Given this list of marker genes IPO11, MLH3 (NCBI Gene Id 27030), AK4, SMARCD1, ASB6, GNE, PRTG, TTI2, XYLT1 (xylosyltransferase 1), TVP23A, ARGLU1, TET3, BNC2, CLCN5, NPY2R, PDP2, MASP1, CASC3, PHETA2, XPO1, OLFM4, ZDHHC23 (zinc finger DHHC-type palmitoyltransferase 23), ITIH5, SEMA4F, AZIN2, HOXA1, FOXRED2, CRY2, PSD3, CBL, EPC1, CBX6, RPS24, CPSF6, KLHL7, DNMT3A, GRIN2A, ARFIP1, TMEM138, DHX58, SF3B4, RBBP7, BMP8A, BLMH, RBFOX1, NALF1, PTAR1, KCNJ5, LIFR, LY6G6C, CLMN, IQSEC2, MLLT11, FAM131B, SH3D19, E2F7, VSIG10, BSPRY, ZNF331, C5AR1, MMP15, NOVA2, ZC4H2, ARHGAP19, SEMA6A, CLDN18, HTR2C (NCBI Gene Id 3358), CD207, PRRC2B, RANBP10, DNM3, KRT31, SCAI, EOMES (eomesodermin), NAV1, GRPEL2, GSG1L, NAV2, USP30, PDE1C, SNX27, TCP11L1, KLHL30, TTLL7, SRGAP3, ZFP3 (ZFP3 zinc finger protein), C5AR2, GLYR1, HMG20A, ELMO2, YJU2, DUSP10, ADAMTS1, ZNF8, NIPAL4, SAMD4B, JPH3, PDE1A, LAMTOR3, COX10 (cytochrome c oxidase assembly factor heme A:farnesyltransferase COX10), NCSTN, CNTN1, KRTAP5-2, CWC27, SNX12, PRDM2, ANTXR2, ASPHD2, ELFN2 (extracellular leucine rich repeat and fibronectin type III domain containing 2), SSH2, SLITRK1, DEDD, ZBTB40, TBC1D8, LENG8, ZRANB1, KDM5A, ZBTB39, HOXB5, ADGRF2P, COL9A2, HAND1, EGFR, OAS2, LPP, FBXO11, CPT1A, AP1S3, PRICKLE2, F8, ADA, CDC14B, ZSCAN22, ZHX3, RTF1, IFIT5, SLA2, C9orf152, IGF1R, SOAT2, PABIR3, NLRC3 (NLR family CARD domain containing 3), PPP2R3A, NFAT5, STAG2, VDR, SRBD1, JUNB, NPTX1 (NCBI Gene Id 4884), HOXB9, FAM117A, DUSP4, KLC2, ADGRL1 (NCBI Gene Id 79732), BPNT1, TMEM178B, FLT3, SETD5, AMMECR1, KIAA1217, SHISA7, VAX1, MYT1L, IRAG1, GUCY1A2, NUB1, MME, CARMIL1, ATXN7L3, ZDHHC22, KCNK9, PGRMC2, P2RY10, RTKN2, WNT1, SCN2A, SPINK14, OPCML, SS18, MPRIP, MTX3, PLXNA4 (plexin A4), BAP1, CAPRIN2, SMARCC1, IGDCC4, KCNH7, TASOR, PHACTR4, STING1, MOXD1, KDM5C, COL1A2, PHF8, FABP7, RAD18, GAS7, FOXJ2, TRAF3IP2, ZBTB4, VAMP3, SELL, AKAP6, TCHHL1, GLUD1, CGN (cingulin), BAALC, ST6GAL1, MYADM, CASP2, FBXO41, OTUD5, TMBIM6, EIF4H, PLPP3, MYSM1, AFAP1L2, MGA, DLG2, GID4, SLC11A2, SHISA6, ARIH2, TMEM214, ANO1, ACKR2, FN3KRP, MLEC, CCDC141, ATP11C, BCL9, ZNF592, SUSD6, MECP2, SSUH2, SYNGAP1, IL5RA, NUDT18, KLHL18, SSU72, POU2AF1, ZBTB20, TAB3, SHISA9, FAM220A, ATG5, NDUFA10, CALCA, SRP54, ADIPOQ, ETV1, SCMH1, AQP4, SERPINB4, KCNG3, PARP11, ABHD2, OTUD6A, CRYZL1, USP39, STAT1, PIGR, IL17D, CIRBP, PIANP, EHD2, LRRTM2, FGD6, ZBTB37, ATP6V1A, FGF12 (fibroblast growth factor 12), HMGXB4, PRICKLE1, GPR173, TMPPE, ALOX15, ZFYVE26, SDK1, CAMK2D, CBX7, ZMIZ2, PDE4A, FAM107A, PPP2R2A, MIEF1, HOXC10, SGPL1, NTRK3, UBQLN2, TIAM1, DCX, ARFIP2, KLHL11, ATRX, EMILIN3, ATRNL1, FLT1, JUN, ELMOD2, ZNF709, SH2B3, KIAA2013, GPATCH2L, JADE2, SPHKAP, IFT56, TNR, ERCC3, SGK1, ERRFI1, IDH3B, RUSC1, OTUD7B, WDR33, SPOCK1, PCNX4, PLEKHS1, TNPO1, ELK4, PNMA2, CNOT8, VTA1, CBLB, DDA1, FKBP7, RGS8, ANKRD13A, ATP6V1E1, LSAMP, ATG16L1, MRPL17, C11orf71, ZMYM5, MYO5C, TMEM40, TMEM184B, NR4A1, ZNF862, HOOK3, here is a description of the gene set: Human Gene Set: MIR4533 species: Homo sapiens Genes predicted to be targets of miRBase v22 microRNA hsa-miR-4533 in miRDB v6.0 with MirTarget v4 prediction scores > 80 (high confidence targets). from publication Chen Y, Wang X (PMID 31504780)